The following is a description of a gene set: Human Gene Set: GOBP_REGULATION_OF_ACTIN_NUCLEATION Any process that modulates the frequency, rate or extent of actin nucleation, the initial step in the formation of an actin filament in which actin monomers combine to form a new filament. studied in species Homo sapiens, and this is the list of marker genes: AP1AR, CORO1A, WASF3, WASF2, ARPIN, WASH3P, CYFIP1, DNAI3, CTNNA2, WASHC2A, WASHC4, WASHC5, ARF1, GSN, WASHC1, WASHC3, GMFG, TRIM27 (tripartite motif containing 27), CARMIL1, WHAMM, CARMIL2, ABI2, PICK1, BRK1, WASF1, WASHC2C, MAGEL2 (NCBI Gene Id 54551), RNH1, CARMIL3, FCHSD2, SCIN, ARFIP2, VIL1, WASH6P, ARFIP1, HIP1R, CORO1B, NCKAP1, GMFB